Given this list of marker genes Atp8a2, Atp9a, Calm1, Atp6v0a1, Ttyh3, Trpm6, Ryr1, Clcnkb, Ano10, Asic5, Atp6v1g3, Atp11b, Casq1, Pln, Scnn1a, Slc17a3, Atp6ap1, Trdn, Pdzd11, Trpc1, Best1, Atp9b, Atp6v0e2, Trpc7, Asic3, Sgk1, Tcirg1, Atp2b1, Atp1a3, Atp6v1d, Atp13a2, Atp13a1, Atp8b2, Scnn1b, Best2, Ano7, Atp2a3, Atp6v0c, Trpc4ap (transient receptor potential cation channel, subfamily C, member 4 associated protein), Atp2b3, Atp8a1, Atp13a5, Ano2, Atp6v1g2, Ubb, Atp1a2, Clca1, Ano4, Atp4a, Atp6v0d1, Scnn1g, Atp6v0a4, Atp12a, Atp6v1e2, Unc79, Trpc5, Trpa1, Slc9b2, Clcn6, Trpv6, Atp4b, Trpm5, Nek4, Trpv5, Mlkl, Atp2a1, Trpv2, Atp1b1, Mcoln1, Best3, Atp6v1a, Asic4, Asic1, Nalcn, Tsc22d3, Rps27a, Trpm8, Ano8, Clcn4, Camk2b, Trpc6, Stoml3, Atp6v0e, Tpcn2, Atp6v1c2, Atp6v1f, Ano9, Ano5, Trpm4, Atp7b, Fxyd3, Fxyd2, Atp2b4, Atp8b1, Atp1b2, Clca4b, Atp1b3, Atp2c2, Fkbp1b, here is a description of the gene set: electronically inferred by orthology from the curated human pathway studied in species Mus musculus part of: Transport of small molecules This event has been computationally inferred from an event that has been demonstrated in another species.<p>The inference is based on the homology mapping from PANTHER. Briefly, reactions for which all involved PhysicalEntities (in input, output and catalyst) have a mapped orthologue/paralogue (for complexes at least 75% of components must have a mapping) are inferred to the other species. Reactome Pathway: Ion channel transport